The following is a description of a gene set: studied in species Homo sapiens Human Gene Set: GOCC_AUTOPHAGOSOME_MEMBRANE The lipid bilayer surrounding an autophagosome, a double-membrane-bounded vesicle in which endogenous cellular material is sequestered., and this is the list of marker genes: RUBCNL, ATG12, WDFY3, CHMP7, IRGM, CHMP5, UVRAG, MAP1LC3C, RAB24, ATP6AP2, CHMP2A, PRKD1, JMY, SH3GLB1, CHMP3, MAP1LC3B2, CHMP1B, RAB30, CALCOCO2, ENTPD4, CHMP2B, CHMP4A, CHMP6, CHMP4BP1, ATG16L1, WIPI1, TMEM74, TECPR1, STX17, ULK1, RAB2B, MAP1LC3A, GABARAPL1, STING1, ATG14, RAB7A, ATG4B, GABARAP, MAP1LC3B, ATG9A, RAB2A, TM9SF1, LAMP2, ATP13A2, CHMP4B, SNAP29, GABARAPL3, VMP1, WDR81, CHMP4C, GABARAPL2, TMEM150B, RB1CC1, MCOLN3, TEX264 (NCBI Gene Id 51368), LAMP1, CHMP1A